The following is a description of a gene set: Human Gene Set: GOMF_G_PROTEIN_COUPLED_RECEPTOR_KINASE_ACTIVITY studied in species Homo sapiens Catalysis of the reaction: ATP + G protein-coupled receptor = ADP + G protein-coupled receptor phosphate., and this is the list of marker genes: GRK5, GRK3, GRK2, GRK4, GRK1, GRK6, GRK7